Given this list of marker genes KAT6B, MYBPC1, RANBP6, TSN, ZNF143, NLRP1, IL31RA, here is a description of the gene set: from publication Chen Y, Wang X (PMID 31504780) Human Gene Set: MIR6814_3P_MIR6872_5P studied in species Homo sapiens Genes predicted to be targets of miRBase v22 microRNA hsa-miR-6814-3p, hsa-miR-6872-5p in miRDB v6.0 with MirTarget v4 prediction scores > 80 (high confidence targets).